The following is a description of a gene set: Mouse Gene Set: GOBP_CHONDROCYTE_DIFFERENTIATION The process in which a chondroblast acquires specialized structural and/or functional features of a chondrocyte. A chondrocyte is a polymorphic cell that forms cartilage. studied in species Mus musculus, and this is the list of marker genes: Chrdl2, Hmga2, Por, Six2, Fgf18, Pth1r, Runx2, Smad3, Scin, Nppc, Chst11, Wnt10b, Bmpr2, Cst5, Osr2, Atf2 (activating transcription factor 2), Mdk, Sox9, Pkdcc, Mapk14, Col3a1, Col2a1, Maf, Ecm1, Osr1, Cytl1, Msx2, Bmpr1b, Hoxd11, Comp, Sulf2, Sox5, Chsy1, Bmpr1a, Tgfbr2, Shox2, Trps1, Ccn2, Gli2, Gpld1, Rflnb, Wnt2b, Fosl2, Grem1, Glg1, Fgfr1, Matn1, Hes5, Bpnt2, Mkx, Axin2, Adamts7, Poc1a, Smad7, Rflna, Runx3, Tgfbr1, Nkx3-2, Efemp1, Serpinh1, Acan, Creb3l2, Rarg, Galnt3, Bmp6, Col11a1, Ltbp3, Rb1, Sox6, Smpd3, Arid5a, Gdf6, Hoxa11, Eif2ak3, Ror2 (NCBI Gene Id 26564), Runx1, Twsg1, Ihh, Mef2c, Zfp219 (NCBI Gene Id 69890), Wnt7a, Scube2, Mex3c, Ctnnb1, Tgfbi, Prkg2, Mboat2, Bmp4, Mia3, Trip11, Sulf1, Adamts12, Gdf5, Ext2, Ccn3, Col27a1, Hspg2, Sfrp2, Rela, Snai2, Mef2d, Chadl, Rarb, Lnpk, Snx19, Fgf9, Col11a2, Nr5a2, Ift80, Scx, Gli3, Slc39a14, Ext1, Thrb, Pth, Ptpn11, Loxl2, Npr2 (NCBI Gene Id 230103), Wnt9a, Pthlh, Ccn4, Nfib, Hif1a, Tgfb1 (NCBI Gene Id 21803), Bmp2, Slc26a2, Prkca, Mustn1, Zbtb16